The following is a description of a gene set: species: Homo sapiens from publication Iparraguirre A, Tobias JW, Hensley SE, Masek KS, Cavanagh LL, Rendl M, Hunter CA, Ertl HC, von Andrian UH, Weninger W (PMID 18029397) Human Gene Set: GSE7831_1H_VS_4H_INFLUENZA_STIM_PDC_UP Genes up-regulated in plasmacytoid dendritic cells in response to influenza virus infection: 1h versus 4h. CpG 1826 binds to Toll-like receptor (TLR)9, whereas influenza virus PR8 activates pDC via TLR7. Differential stimulation of pDCs is expected to result in unique activation mechanism(s) leading to a different phenotypically and functionally matured pDC We used microarrays to detail the global programme of gene expression underlying the maturation process of pDC activated with CpG 1826 and influenza virus PR8. We identified a distinct expression profile of upregulated immunomediators., and this is the list of marker genes: GORASP1, GHDC, PFKL, CBX7, GSTM3, SH3YL1, CRELD1, SPO11 (NCBI Gene Id 23626), TSSC4, NPR2, DFFA, FAAP20, PLXDC2, ITGA2B, EPB41, WDSUB1, PKN3, FAM219B, ACTR1A, ZC2HC1A, SGMS1, FAHD1, TMEM205, TADA3, ITSN1, RAB27B, GRB10, RAI14, RAD54L2, CTNNAL1, AKAP8L, DUSP4, SRSF12, FADS2, FKBP9, ALDH1L1, HTATIP2, FSTL1, AKR1E2, AP4B1, OSBPL1A, ADGRD1, JOSD2, PDCD11, GALM, CTSH, TACSTD2, ATF4, SDR39U1, DLG3, AFDN, ITGA6 (NCBI Gene Id 3655), B4GALNT4, LIX1L, CCRL2, FLOT1, CCDC85B, TEK, AMOT, TLE6 (TLE family member 6, subcortical maternal complex member), CBR3, YRDC, ALDOC, ABHD14B, SUSD1, PGAP4, IL11RA, S100A1, FKBP14, TRPC4AP, ZNF23, SLC25A24, IER5, TNIP1, CAVIN2, ZDHHC7, SERTAD1, C22orf39, SH3PXD2B, EYA2 (EYA transcriptional coactivator and phosphatase 2), COL4A2, GFI1B (growth factor independent 1B transcriptional repressor), WSB2, RGS1, AFAP1L1, VDR, P2RX1, CDADC1, TIMM10B, BDH2, ASCC1, SUGT1, ARHGAP12, MRPL52, MECOM, APBA3, RBCK1, CERS4, ZFPL1, RELA (RELA proto-oncogene, NF-kB subunit), SMAGP, COL16A1, NDP, LMBRD1, KDM3A, TTC4, ADRB2, TUFM, BRF1, REC8, MAMDC2, HMGCL, PCLO, CORO1B, KYAT1, CD9, PRCP, SLC48A1, RBM19, INPPL1, DCLK3, SGK1, WWP2, CNPY3, ACOT11, INF2, PTOV1, NAT9, THY1, TBC1D9, RAD23A, AQP1, PLXNC1, S100A6, MMP14, FOSB, LCP2, RAB20, FAM210B, DBNL, SORBS1, TMEM140, C9orf152, CD99L2, FBXO30, KLF6, FSCN1, LUZP1, RO60, ALS2, SLC37A1, ACSS2, PPARGC1A, TGFBI, DENND1A, PITPNM1, BEX4, HEBP1, IFITM3, NOP2, NOMO1 (NCBI Gene Id 23420), GTF2I, UBE2Z, CDCP1, MTURN, CDC42EP4, VAMP2, C1QTNF12, TANGO2, KLF9, GPR107, CARD19, TCEAL1, TTC38, CCDC51 (coiled-coil domain containing 51), RHBDF1, ERGIC3, LAIR1, JUNB, MED8, GEM, SGCE, NCKAP1, IRAK3, CPXM1, KAZALD1, FLOT2, APP, SLC6A15, ISG20, GBP2, ARRB1, UAP1L1, MYCT1, TAPBP, H1-0, ACSF3, TSPYL5, MYOF, GSTT1